Given this list of marker genes Oaz1, Psma4, Psma7, Azin2 (NCBI Gene Id 242669), Oaz3, Psmd12, Oaz2, Agmat, Psmd13, Psmc1, Nqo1, Odc1, Psmc3, Psma1, Psma3, Psmb7, Psmd1, Psmc6, Psmb4, Psmb6, Sat1, Psmb5 (proteasome (prosome, macropain) subunit, beta type 5), Psma6, Psma5, Psmc2, Psma2, Psmc4, Psmd7, Psmd6, Psmc5, here is a description of the gene set: part of: Metabolism of amino acids and derivatives Reactome Pathway: Metabolism of polyamines This event has been computationally inferred from an event that has been demonstrated in another species.<p>The inference is based on the homology mapping from PANTHER. Briefly, reactions for which all involved PhysicalEntities (in input, output and catalyst) have a mapped orthologue/paralogue (for complexes at least 75% of components must have a mapping) are inferred to the other species. species: Mus musculus electronically inferred by orthology from the curated human pathway